Given this list of marker genes TPP2, MTHFR, DPYSL3, SUCLG1, TRIM25, HCFC2, EIF4E2, SARS1, H2BC21, CACNG3, PAX3, MCCC2, DDB1 (damage specific DNA binding protein 1), HOXD3, PPP1R12A, PDGFB, VCP, OAZ1, CUTA, RBL1, MAP2K7, FADS3, PALS2, TYMP, HSP90B1, PIAS1, BLZF1, FTSJ1, METTL1, RPL9, RIGI, NFS1, PKM, MDM2, CRAT, NUBP1, GPR132, SAP30, RLN1, ILK, SNAPC1, CDKL3, ATF7, H2BC10, PRMT5, ARID4A, LMNA, CCHCR1, AMPD2, QDPR, GNL3, MOCS2, CCT8, RPS15, IRF3, NID1, NRAS, ATP5MC2, ESD, MTERF1, CTSC (cathepsin C), CWC27, TGFB2, LSM1, AIFM1, RABGEF1, SUPT5H, PRDM8 (PR/SET domain 8), SQSTM1, H2AC13, THAP12 (NCBI Gene Id 9137), FGFR4, VASP, RHEB, SGPL1, CAD, VGF (NCBI Gene Id 7425), FGF9, MKNK1 (MAPK interacting serine/threonine kinase 1), FASN, KPNA3, SNX3, PCBD2, RAC2, H4C2, KIAA1586, CR2, UCP1, ALDH2, HDAC3, RBM39, POLB, HINT1, KIF20B, PDE4C, KHK, USPL1, ATP5PO, HMGN2, DLEU1 (NCBI Gene Id 647154), NUP153, MTPN, HAX1, BUB1, GTF3C4, PTMA, NIT1, ERO1A, RNFT1, SMARCAD1, PLOD3, H2AC7, TOP1, ACE, HBA1, CRIPT, PSMD8, SERTAD1, USP4, GPN3, WDR36, RPS27L, GLA (galactosidase alpha), ALG5, ZNF146, CACYBP, RAB3A, PPP6C, SLIT1, PMS2P3, GTF3C5, MNX1, CDK6, POLD4, ZNG1A, H2BC17, NDUFB6, INSR, PYCR2, FAH, ZNF593, MPC1, INSM1, ELOA, RNF141, CDK16, RECQL5, APC, NDUFB3, SLC2A4RG, HDAC6, SERPINE1, IFRD2, NUP54, SRI, SNRNP40, HSPA8, TMEM187, LAIR1, SERP1, PCNA, NHERF2, RHOG, PMM2, MOCS3, BIRC6, PPIA, CREB1, DPM1, NUBP2, IRF2, ZNF234 (zinc finger protein 234), CALM2, TUSC2, NUP62, BCCIP, BLM, COL4A1, MYCBP (NCBI Gene Id 26292), TULP3, ADCY9, CYTH2, CNOT9, SRSF2, ATP6V1D, PDK2, SLC4A2 (NCBI Gene Id 96677), SPIB, PFN1, GALC, UCP3, RXYLT1, RIOX2, CCT5 (chaperonin containing TCP1 subunit 5), CIB1, CEP83, CMAS, ITGB1, EIF2S3 (NCBI Gene Id 8422), VAMP1, IRF9, SEC23B, VPS52, RPS21, SRP68, UCHL1, TAGLN2, ING1, IL17C, NFKBIB, CLCN3, RIPK2, H2AC14, PRKAB1, ERCC6, CEACAM5, ACOX1, MTOR, PTPN1, NACA, PIK3C3, SNRPA, GLT8D1 (glycosyltransferase 8 domain containing 1), RPS6KA5, POLD2, APPL1, PSMA5, ATP5F1C (ATP synthase F1 subunit gamma), RPL32, SCAMP3 (NCBI Gene Id 255017), TOB2P1, RFX5, SRSF11, LTB, EIF2S1, SYK, NBN, PARG, ASB1, AP4S1, CCL14, CALR, SIM2, EIF3I, AP4M1, SLC26A4, CNOT4, RNF4, SLC28A2, PIGP, DYNC1LI1, UBAC1, IER5, PLA2G6, CDK4, IMPA2, RFC2, ATP5F1E, POU2F1, FOXM1, BBC3, PHB2, MAGEF1, MCL1, MARS1, NFAT5, TFRC, PTGES3, ZFP36L1, HES1, POLR1H, TIMM10, ASB16, SYMPK, FANCF, SFXN3, DPY30, PPP1R7, DCTN3, PYCARD, SRRM2, PPP1R12C, HBA2, RPL27A, CHRNB1, NOD1, DDX41, DCTN4, DDX3X, H4C13 (H4 clustered histone 13), MAPRE1, HNRNPDL, PCM1, PRKCSH, ELOVL1, H2AC6, HS3ST2, GINS2 (GINS complex subunit 2), VDAC2, MCM5, UBA52, LTA4H, ZNF410, PTDSS1, SDF2, CISH, RAD54L, PRTN3, PPT2, TERT, MAP4K5, LIPT1 (NCBI Gene Id 51601), ITGB3BP, UBE2G2, EIF5A2, EPC1 (NCBI Gene Id 80314), MUC5B, PPID, HLA-DRB3, PFDN6, RAD51AP1, HSF2BP, PER1, H2AZ1, DAP3, PCNP, MCM3, PDE6D, GOLPH3, PMS1, SNRPB2, APBA3, UXT, MUC1, ULBP1, LBR, SRSF1, MKRN1, ZSCAN9, DIABLO, H2BC14, FRY, GCLC, ENTPD7 (NCBI Gene Id 57089), CCNB1, ASCL2, ISG20 (NCBI Gene Id 3669), RPL13A, KLF1, SLC39A6, GTF2H2 (NCBI Gene Id 2966), PSMD7, STMN1, LANCL1, ODC1, SPAST, RAB8A, GDE1, TUBG1, VDAC3, CSF2RB, RPL22, PSMB5 (proteasome 20S subunit beta 5), VAMP2, TMEM126A, DLEU2, PFKFB4, H2AX, SERPINE2, VAPA, POLR1B, NCBP2, MAN2A2, ZNF274 (NCBI Gene Id 51732), PWP1, SCD, CBX3, E2F3, STX10, PAPPA, MBNL1, PPP1R3D, SLC12A2, DBI, CIAO1, MBD4, MKLN1, ARSB, PPP2R1B, RBM15B (RNA binding motif protein 15B), STAT6, SERF1B, MMP8, VPS29, GSTO1, KLK10, PYCR1, HMMR, ICAM1, DPAGT1, YBX3, NOP2, LAMC1, H2BC7, UBE2K, ELK1, CACNB1, BZW1, BARD1, AMMECR1 (AMMECR nuclear protein 1), MANF, HSPA4, DDX10, IL2, ARL6IP5, NOL7, ALDH9A1, ACO2, NDUFB4, TGFB1, PPP2CA, ERBB2, ENOPH1, SLC22A3, MEIS2, RNPS1, NPRL2, DPM2, GABARAP (GABA type A receptor-associated protein), PARP1, MAGOH, LAMTOR5 (late endosomal/lysosomal adaptor, MAPK and MTOR activator 5), DEGS1, ATXN10, PTPA, H2AC18, EIF4H, NEFM, ZKSCAN8, CSDE1, FPGS (folylpolyglutamate synthase), NDUFB5, ABT1, ACSS2, SCAND1, MBD1, UROD, POLR3K, NUP88, NDUFA1, CD63, ASH2L, LAIR2, PDCD10, TSC2 (TSC complex subunit 2), HSPE1 (heat shock protein family E (Hsp10) member 1), RPL3, DMAP1, YWHAH, BTBD1, SAP18, RNF7, SLC5A6 (NCBI Gene Id 8884), OGA, GEMIN2, HNRNPUL1, GDAP1 (NCBI Gene Id 54332), AMD1, POLR1D, NOTCH4, PSMC4, FXN, METTL13 (NCBI Gene Id 88158), H4C14, EIF3K, TOPBP1, RARA, MRTO4, TGFB3, SMC1A, PSEN2, USP1, EPHX1, ARFGAP2, NCL, SLC31A1, RAB5IF, LSR, H2BC9, AKAP10, SCML2, SLC7A1, AQR, STUB1, EGR3, APP, H2BC12L, DCAF8, OCIAD1, ZNF7, NCAPG, AP4E1, ZNF136, CCKBR, CXCL2, MAEA (NCBI Gene Id 10296), WDR46, DMTF1, MSN, EPM2A, MAFF, GALT, ZKSCAN5, CLN3, HIF1A, CLINT1, RNASET2, IL13, JUNB, PMVK, MACROH2A1, CRADD, BLK, PHB1, HADHB (NCBI Gene Id 3032), POLE3, PTOV1, NAT10, NFIL3, P3H1, CDC6, CYTIP, RAD51, EXO1, SLC22A4, SCLY, DDX1, HSPA9, PPA1, MAP2K5, COL4A2, SREBF2, PEX16, MMP15, MDH1, ACP3, CDC16, RAP2B, MRPL40, MIR155HG, RBBP8, PNO1, SLC25A28, TGIF2, RPS25, SPTLC2, TRAP1, PSMD5, GAPDH, SLC43A1, SNX5, PARP2, MAGEA3, ERF, PSMG1, SRPRA, PPFIA1, RSL24D1, TIMM23B, PPP3CA, ATP6V1G2, CEBPZ, PSMB7, DKC1, SLC19A1, U2AF1, RECQL (RecQ like helicase, NCBI Gene Id 5965), FUT1 (fucosyltransferase 1 (H blood group)), RAB3GAP2, TRIB1, RPS20, CBS, RPL31, TK1, CST5, HERC1, CD164, SLC25A3, ATG12, PDPK1, SPAG6, ATF4, KIF20A, LZTR1, ZNF451, EIF4A1, HOOK2, GAK, NAP1L1, MT2A, CYB561D2, ACAD8, HLA-F, FBXO5, MLXIP, EIF4EBP2, SRP54, NAGPA, HMOX1, EIF4E, TCIRG1, PAIP2, PRKDC, CREBL2, AKAP1, SLC25A11, MYCT1, LSP1, PA2G4, MTHFD1, RPL13, AMPD3, ATM, DCK, LZTFL1 (NCBI Gene Id 54585), GNB1L, CORO1C, FKBP2, CLUL1, LMX1B, LDHA, ERLIN1, SUPT16H, CD79B, MYCL, ARFIP2, RGL2, ARRB2, CXXC1 (NCBI Gene Id 54105), AP4B1 (adaptor related protein complex 4 subunit beta 1, NCBI Gene Id 10717), CD2AP, RAPGEF6, LAMP1, SLBP, AIMP2, ZNF174, UBQLN1, NME2, GOLGA5, POLH, MEN1 (NCBI Gene Id 4221), RPS17, LNPEP, H2BC4, RIPPLY3, USP11 (ubiquitin specific peptidase 11), SIGMAR1, ATF6, SDF2L1 (NCBI Gene Id 23753), ABCC4, AKR7A2, ARF4, UBE2D3, SPAG5, SOD1, WDR4 (NCBI Gene Id 55896), HNRNPA2B1, PLA2G4A, MELTF, SHMT1, CCT7, STOML3, FOSL1, CEBPA, APEX1, RPS27A, TMED10, NCBP1, PQBP1, IFNGR1, ACTR3, ACHE, PTGER2, WDR5, MAPK7 (mitogen-activated protein kinase 7), MAP3K20, SP4, ASAH1, EMC8, RPL5, NDUFA6, RPL10, CDKN2B, ANAPC10, ABI3 (ABI family member 3), HSD11B2, DNAI1, COPS3, ACADM, TXN, MGST1, HERPUD1, BAZ1B, DDX5, BAX, SSB, ACTG1, PRDX5, FXR1, PSMA1, PEX11B, CDC25A, ZMPSTE24, RPS29 (ribosomal protein S29), THBS4, ELL, ZNF225, MYC, SNAPC3, RPS19, PSAP, PSMD10, FZD5, CPSF1, EPB42, SUGT1, H2BC15, RPL19, UBE2C, SH2D3C, TTC4, HMG20A, CHERP, CCND2, RCC1, GPR4, NUFIP1, CSTF3, PTPN6, DGCR6, ABCB6, DDX17, TRMT6, H2AC15, HNRNPA1, WT1, PRPSAP1, GMIP, PDK3, RPL15, SRSF5, EEA1 (early endosome antigen 1), GAL, SNRPD3, BCL2L12, SLC1A4, NBR1, PSMD14, H2BC11, NTHL1, AGPS, RPL18, RARB, COX7C, HSPA14, NUP155, USO1, ARPP19, DDX18, MYBL2, ARFRP1, GNA12, SIRT1, CLCN2, LSM8, POLR3G, RPL37, MAT2B, MED17, IFI30, UBXN1, PREP, NDUFS1, FXR2, IGKC, MST1R, PDHA1, ETF1, RXRB, KDM5C, LAGE3, THRAP3, HARS1, PSMB1, STYXL1 (NCBI Gene Id 51657), BCKDHB, PCYT1A, MAP3K5, POMT2, GSK3B, MCM7, GCFC2, PPP1CB, PSMC5, U2SURP, HMBS (hydroxymethylbilane synthase), RPL8, DNTT, ARHGEF7, RBM4, PTP4A1, MTF2, TCF12, GINS1, HBP1, ACYP2, IDH3B, ACOX3, AZIN1, NR1D1, C9orf43, BCL3, TIMM8A, IER2 (NCBI Gene Id 9592), CNDP2 (NCBI Gene Id 55748), CTDSP1, NXT1, NAGA, CKS2, NDUFS6, RPS26, ZNF544, ATP5F1B, XK (X-linked Kx blood group antigen, Kell and VPS13A binding protein), MGAT2, MPO, ADGRE5, TIMM9 (translocase of inner mitochondrial membrane 9), WNT10B, TYK2, CYBA (NCBI Gene Id 1535), STX16, STK26, RPS6, COX15 (cytochrome c oxidase assembly homolog COX15), JRKL, PIGF, MAPRE2, TRMT13, ENO1, GLRA3, ZFP36L2, PPAT, ADAM22, ENO2, RPS13, CDC25C, CASP8AP2, SLA, DDX11, PKP1, HSPD1, RAB1A, RBM3, ZNF85, MET, ID3, GAS8, H6PD, RPS5, PRKAB2, H2AC17, PEX3, EMP1, ZFPL1, IGBP1, POLR3D, H4C5, H4C4, DRG1, CUL5, MEIS1, ARPC4, CHD1L, HBB, ID2, AVP, KEAP1, PEX6, SRSF7, PARP3, SLC39A7, SEC61B, TP53, FECH, SEC62, SAE1, CBX5, NME1, PKN2, XRCC6 (NCBI Gene Id 94359), SCOC, MAT2A, KHSRP, SHPK (sedoheptulokinase), NTN3, NR6A1, RGS2, DAXX, GASK1B, SMAD3, NBR2 (neighbor of BRCA1 lncRNA 2), PCMT1, RPL27, ST6GALNAC4, ARL1, TRAPPC3, PLA2G15, NDUFB2 (NCBI Gene Id 4708), OCA2, RANBP3, MSH2, HSP90AA2P, KCNH4, SRM, PSME3, DBP, E2F1, GNS, UBL3, ABCB10, BMP4, M6PR, SYPL1, CSTB, MST1, ZNF35, DMAC2L (distal membrane arm assembly component 2 like), PINK1, UQCR10, GSTP1, ZNF304, RPS16, ITGA6, UQCRC2, SURF6 (surfeit 6), CIR1, CEPT1, MAD2L1, TLE3, DNAJA2, TLL2, HOXD13, BIRC3, CNPY2, CTSF, MAN2A1, RPS6KA2, SMN1, PEX14, PMPCB, RPL26, RIDA, ZNF12, RPS6KB1, CLCN6, ALOXE3, GPSM3, COPS2, H2BC6, TSEN34, ARF1, CD180, CH25H, UBXN8, NFKBIL1 (NCBI Gene Id 4795), H2AC11, MFAP1, EIF4B, CNTN2 (NCBI Gene Id 6900), AHCYL1, CDKN1B, JARID2, MPHOSPH6, NPM1, FLOT2, DFFA, YIF1A, GRK4, H2BC8, HMGA1, NDRG1, NUDT6, ACP5, ATP1A2, SMAD7, ZNF142, PRKRA, HLA-DPB1, PAICS, LATS1 (large tumor suppressor kinase 1), AKR1A1, BTN2A1, RCL1, TESK2, SFMBT1, PRDX3, ZNF134, TYMS, SCO1, ZNF271P, MT3, DEF6, IL11RA, EXOSC8, CLP1, RRAS, TNFAIP1, IVNS1ABP, SYNGR2, RBBP4, CFDP1, CAPZA1, AKAP9, MADD, TTC33, POLR3A, MFNG, RRAGA, NDUFA2, COX7A2L, GATB (glutamyl-tRNA amidotransferase subunit B), RAB11A, GNL1, SLC25A40, ZPR1, SOX12, YY1, AHSG, SNRPB, KIF15, CASP9, SRD5A1, PRPS2, GMDS, EIF3C, EEF1E1, CDC25B, BCAT1, NGB, CCDC6, KDM5A, SLC39A8, RBM8A, ETFA, VHL, GABPA, PSMD3, BSG, IFNAR1, here is a description of the gene set: Human Gene Set: DANG_BOUND_BY_MYC species: Homo sapiens from publication Zeller KI, Jegga AG, Aronow BJ, O'Donnell KA, Dang CV (PMID 14519204) Genes whose promoters are bound by MYC, according to MYC Target Gene Database. We report a database of genes responsive to the Myc oncogenic transcription factor. The database Myc Target Gene prioritizes candidate target genes according to experimental evidence and clusters responsive genes into functional groups. We coupled the prioritization of target genes with phylogenetic sequence comparisons to predict c-Myc target binding sites, which are in turn validated by chromatin immunoprecipitation assays. This database is essential for the understanding of the genetic regulatory networks underlying the genesis of cancers.